Given this list of marker genes Hmox1, Ppargc1a, Wnt11, Selplg, Tia1, Gsn, Sfrp4, Spop, Eif2s1, Sort1, Jak2, Pias4, Carm1, Bad, Mtor, Sav1, Pla2g1b, Arrb2, Hdac3, Capn10, Ager, Pla2r1, Bax, Isl1, Stk4, here is a description of the gene set: species: Mus musculus Any process that activates or increases the frequency, rate or extent of epithelial cell apoptotic process. Mouse Gene Set: GOBP_POSITIVE_REGULATION_OF_EPITHELIAL_CELL_APOPTOTIC_PROCESS